The following is a description of a gene set: studied in species Homo sapiens from publication Kerkar SP, Goldszmid RS, Muranski P, Chinnasamy D, Yu Z, Reger RN, Leonardi AJ, Morgan RA, Wang E, Marincola FM, Trinchieri G, Rosenberg SA, Restifo NP (PMID 22056381) Genes down-regulated in B16 melanoma during adoptive transfer therapy: day 3 versus day 7. Human Gene Set: GSE29164_DAY3_VS_DAY7_CD8_TCELL_AND_IL12_TREATED_MELANOMA_DN Myeloid-derived cells comprising the tumor stroma represent a heterogeneous population of cells critical to the structure, function and growth of established cancers. We have recently found that engineering tumor-specific CD8+ T cells to secrete IL-12 (IL-12TD) can lead to striking improvements in T-cell activity against established melanomas in murine models. Surprisingly, IL-12-dependent enhancement of CD8+ T-cell anti-tumor function did not occur through direct ligation of receptors on lymphocytes or NK cells. Instead, IL-12 sensitized host bone marrow-derived tumor-stromal cells, partly through interferon-gamma, to indirectly enhance the effects of adoptively-transferred T cells. Direct presentation of antigen by tumor was not necessary, but MHC class I expression on endogenous cells was essential for IL-12 mediated anti-tumor enhancements. Upon successful treatment with IL-12TD cells, we observed the selective elimination of tumor-infiltrating CD11b+ F4/80+ macrophages, CD11b+/ClassII+/CD11c+ dendritic cells and CD11b+/Ly6C+/Ly6G- but not CD11b+/Ly6C+/Ly6G+ myeloid-derived suppressor cells within regressing lesions. These results are consistent with a model whereby IL-12 triggers the maturation of myeloid-derived cells into competent antigen cross-presenting cells. Licensed recognition of these antigens by effector T cells may in turn trigger the collapse of the tumor stroma and aid in the regression of large vascularized lesions., and this is the list of marker genes: GGT5, LGR6, ISCU, ARRB2, KRT72, PPFIA4, HOXA7, MDH1B, MDH2, NKD1, HDAC7, FGL2, NGF, KPRP, FAM163A, CUL7, COL5A3 (NCBI Gene Id 50509), MPST, DYNC1LI1, RAB11FIP4, CCDC83, VWF, TMEM74, PACSIN3, TP53I11, ELOVL3, NOP16, CERCAM, TIMM10B, TNFRSF13C, COL27A1 (collagen type XXVII alpha 1 chain), PIEZO2, CDC42EP2, PCP4, ZNF784, GABRG2, ATP5PO, SYPL2, CNPY3, LRFN1, CRB1, MT3, ARHGEF25, TTR, RNF122, HGS, RAB1B, LEPR, RTN4RL1, PRKCB, MYO1E, MTLN, COL2A1, SPAG6, UBXN8, KLRK1, ALDH1A2, TNXB (NCBI Gene Id 7148), DCC, TEX15, S1PR1, CPA3, CASP14, CSF3, ZFP36 (NCBI Gene Id 7538), SCAPER, KCNE5, ZFP36L1, SYCN, OXTR, FGD2, PRTG, OXT, LIM2, HSD17B8 (NCBI Gene Id 7923), PDZK1IP1, RAB37, KCNT1, ITPR3, SLC27A2, SPATA18 (NCBI Gene Id 552857), LY75, TTC39B, ARPC1B, OR52A1, COL1A2, DCDC2, FNDC5, SRXN1, WDR83OS, NECTIN1, SHB, TBC1D22B, LRRN1, SLC5A5, BCAT1, CX3CL1, ANK1, CCT8L2, PAK1, NCCRP1, ZFP37, PPIL2, AKT1S1, DNM2, JAK3 (Janus kinase 3), KDM6B, CD244, BDH1, PPP1R3F, COMMD3 (NCBI Gene Id 23412), SERINC4, GPA33, AOC1, LYPLA2, MEIKIN, TAP2, LFNG, SAMD4B, TUFT1, TMEM150C, UNC5C, LIX1, CD80, PDGFC, SLC44A2, RHOF, C1QL2, DNAJB13, HLA-DRA, OMG, BTBD19, ENDOV, FAAH, AKR7A2, RARG, SCD, RPL36A, STK32C, TFF1, CFAP20DC, IQCA1, B3GALT5 (NCBI Gene Id 105372805), CR2, TMEM52, GPBP1L1, GPR45 (G protein-coupled receptor 45), ZDHHC14, RNF167, AHSG, ELN, LTBP2, HECTD2, NDUFA6, PVT1, SCNN1B, COMMD4, MRPS16, ACOT7 (NCBI Gene Id 11332), MIF, DPP10, FYN, FBXO36, CSMD3, MPPED1, ERG, KCNJ9, PSMB8, CFD, H1-10 (H1.10 linker histone), C11orf86, SIX2, ZFPM2, NACC1, STAU2, EVI5L, CNP, MOB2, GAST, SEC61G, SGSM2, FXYD1, FMO3, LCP2, IL31RA, IL7R, IGDCC3, SERPINB2, AIG1, HYOU1, ZNF475, TMEM63B, ALPK2, JUP, FUNDC1, KRT80, SLC30A4, TMEM14C, CYBRD1, GPRC6A